Given this list of marker genes Ccr2, Mmp2, mt-Cytb, Cat, Bnip3, Cav1, Kcna5, mt-Atp6 (NCBI Gene Id 98563), Col1a1, Polb, Sod2, Cyp1a1, Foxo1, Slc7a5, Epo, Nox1, Fas, Atg7, Cdkn1a, here is a description of the gene set: Any process that results in a change in state or activity of a cell or an organism (in terms of movement, secretion, enzyme production, gene expression, etc.) as a result of a stimulus indicating increased oxygen tension. Mouse Gene Set: GOBP_RESPONSE_TO_HYPEROXIA studied in species Mus musculus